The following is a description of a gene set: Genes in the cancer module 65. Human Gene Set: MODULE_65 studied in species Homo sapiens, and this is the list of marker genes: NPR1, GUCY2C, PDE5A, ADM, GUCY1B1, ADCY8, GUCY2D, GUCY2F, GUCY1A2, NPR2